The following is a description of a gene set: Any process that modulates the frequency, rate or extent of protein localization to lysosome. studied in species Homo sapiens Human Gene Set: GOBP_REGULATION_OF_PROTEIN_LOCALIZATION_TO_LYSOSOME, and this is the list of marker genes: GPR137B, LAMTOR1, AKT1, ROCK2, MEAK7